The following is a description of a gene set: Mouse Gene Set: GOBP_MACROPHAGE_ACTIVATION_INVOLVED_IN_IMMUNE_RESPONSE studied in species Mus musculus A change in morphology and behavior of a macrophage resulting from exposure to a cytokine, chemokine, cellular ligand, or soluble factor, leading to the initiation or perpetuation of an immune response., and this is the list of marker genes: Ifnb1, Ifi35, Cx3cr1, Tyrobp, Trex1, Dysf, Grn, Nmi, Hmgb1, Trem2 (NCBI Gene Id 83433), Havcr2 (NCBI Gene Id 268402), Il33, Ticam1, Prkce, Sbno2, Tnf, Plcg2 (phospholipase C, gamma 2), Syk, Lbp (lipopolysaccharide binding protein), Sucnr1, Ifng